Given this list of marker genes Mocos, Nfs1, Mocs1, Mocs3, Gphn, here is a description of the gene set: studied in species Mus musculus Molybdenum cofactor biosynthesis Mouse Gene Set: REACTOME_MOLYBDENUM_COFACTOR_BIOSYNTHESIS